Given this list of marker genes MGAM, TRPM2, CLEC4D, LILRB2, CHRNB4, LAMTOR2, SVIP, SLC2A3, LILRA3, NBEAL2, CYSTM1, CYBB, RAP2B, GPR84, ITGB2 (NCBI Gene Id 3689), DYNLL1, ATP6AP2, GAA, CEACAM1, FPR2, NRAS, COPB1, CEACAM8, PLD1, FCER1G, CD93, TMC6, TARM1, SNAP23, TMEM63A, ADAM10, CD177, SIGLEC14, ATP8B4, VAMP1, ANO6, CLEC4C, SLC11A1, FCAR, MCEMP1, ADAM8, CD47, LAMTOR3, UBR4, HGSNAT, CLEC12A, CD33, RAB14, PTAFR, SERPINB6 (serpin family B member 6), ITGAM, OLR1, PTPRB, CLEC5A, CD300A, SIRPA, CYBA, ITGAX, RAP2C, PLAU, ATP11A, TSPAN14, SIGLEC5, STBD1, VAMP8, CD53, LAIR1, KCNAB2, ATP6V0C, FRMPD3 (NCBI Gene Id 84443), STOM, CD59, SNAP25, here is a description of the gene set: The lipid bilayer surrounding a tertiary granule. studied in species Homo sapiens Human Gene Set: GOCC_TERTIARY_GRANULE_MEMBRANE